Given this list of marker genes SOS2, PAK6, PAK3, PAK1, PAK2, NCK1, ROBO1, SOS1, PAK4, RAC1, SLIT2, NCK2, PAK5, here is a description of the gene set: Activation of RAC1 Human Gene Set: REACTOME_ACTIVATION_OF_RAC1 species: Homo sapiens